The following is a description of a gene set: Human Gene Set: ZHANG_BREAST_CANCER_PROGENITORS_UP species: Mus musculus Genes up-regulated in cancer stem cells isolated from mammary tumors compared to the non-tumorigenic cells. Using a syngeneic p53-null mouse mammary gland tumor model that closely mimics human breast cancer, we have identified, by limiting dilution transplantation and in vitro mammosphere assay, a Lin(-)CD29(H)CD24(H) subpopulation of tumor-initiating cells. Upon subsequent transplantation, this subpopulation generated heterogeneous tumors that displayed properties similar to the primary tumor. Analysis of biomarkers suggests the Lin(-)CD29(H)CD24(H) subpopulation may have arisen from a bipotent mammary progenitor. Differentially expressed genes in the Lin(-)CD29(H)CD24(H) mouse mammary gland tumor-initiating cell population include those involved in DNA damage response and repair, as well as genes involved in epigenetic regulation previously shown to be critical for stem cell self-renewal. These studies provide in vitro and in vivo data that support the cancer stem cell (CSC) hypothesis. Furthermore, this p53-null mouse mammary tumor model may allow us to identify new CSC markers and to test the functional importance of these markers. from publication Zhang M, Behbod F, Atkinson RL, Landis MD, Kittrell F, Edwards D, Medina D, Tsimelzon A, Hilsenbeck S, Green JE, Michalowska AM, Rosen JM (PMID 18559513), and this is the list of marker genes: WDR3, RBBP5, VPS26B, ZFAND4, TOMM70, ECT2, WEE1, CTDSPL2, ADAMTS20, ITGA6, ACYP1, SESN3, SERBP1, KBTBD8, ADGRL3, TCEA1, CAPRIN1, TAF1D, LZTFL1, STMN1, C11orf54, NCBP1, CTTNBP2, COL25A1, PTPN14, UCHL5, SERTAD4, DSG2, TGFA, MLLT3, DEPDC1 (DEP domain containing 1), SRSF3, PSPC1, WDR75, MARCHF6, NFIA, SFPQ, CALM2, POT1, NUP155, ZNF770, RRAGD, ARPP19, BCAP29, IFTAP, MELK, SLC20A2, NFYB, SMNDC1, AUTS2, ACSL3, TIMM17A, LCORL, ZNF367, FAM13B, DUSP11, ARAP2, C1D, MOB4, AP1S3, PPM1B, INTS2, WIF1, MET, NRAS, ABHD13, ZNF362, HNRNPLL, ADK, ARMC10 (armadillo repeat containing 10), SMC4, GPSM2, CDC73, UBE2B, ARNT2, SMCHD1, SBNO1, SEC22C, LSM5, ZNF148 (zinc finger protein 148), HACE1, RPA3, ALG13, ZNF267, CEP43, TIMM21, IPO8, TMEM209, PEX7, SYNCRIP, CRLS1, CEP192, EPS8, LSM7, MYB, STRAP, LRRC40, TRMT6, FGFR1OP2, GMNN, EDARADD, SYDE2, NUP85, LAMTOR5, ANAPC1, PATZ1, ACTL6A, HMGB2 (NCBI Gene Id 3148), NCAPD2, FIRRM, CAV2, POLD3, SETX, PLEKHB1, CNOT6, MDH1, MCM2, YWHAB, CHMP1B2P, TTF2, RIF1 (NCBI Gene Id 55183), TRIM37 (tripartite motif containing 37), TRPM3, TP53BP1, EIF4B, MME, AZIN1, SLC7A1, LRBA, SNX5, ILF3, RBBP8, MRPS31, ANP32E, PIN1, WDR11, SEMA5A, PIGF, BUB1B, CHEK1, N4BP2, MIS18BP1, RNF128, YWHAQ, ZBTB44, PRR14L, MATR3, HELLS, TMTC4, ARL6IP6, CTH, KITLG, NVL, VPS54, SKP2, CTNND2, TRDMT1, FARSB, CAPZA2, PCDH18, UNG, SGO1, RPS3, PSAT1 (NCBI Gene Id 29968), USP34, IMMP1L, TMEM230, MTDH, G3BP2, XRCC5, CDC40, HNRNPDL (heterogeneous nuclear ribonucleoprotein D like), POLA1, TRRAP (transformation/transcription domain associated protein), EFCAB7, RRM2, AJUBA, NUDCD1, MRPS18C, VBP1, BRCA1, ZNF160, ZNF239, TCEANC, BBIP1, STK26, HOOK1, SKA2, PPIP5K2, SLC38A1, COL4A5, HNRNPA2B1, SLC39A10, ZNF24, GPM6B, TTC9C, SHCBP1, MAP7D2, TRAPPC2, SNRPB2, ETFRF1, CDCA8, ING3, UBLCP1, IDH3A, RPS6KA6, ZC3HAV1L, TOP2A, RPA1, PARK7 (NCBI Gene Id 113880), ACTR3B, RAD21, MOXD1, C1orf74, CENPF, CFAP97, JADE1, EIF4H, DBF4, OXCT1, TRIP13, HAT1, VDAC1, ENPP3, AEBP2, SAP30, PARP1, UHRF1, BET1 (NCBI Gene Id 10282), POLR3K, BCL2, AURKA, TRIM59, PFN2, ERI2, CSTF2, PKP4, DCK, ZCCHC8, CETN3, EDAR, PHB2, UBA3, POLR3H, TSPAN13, NEO1, ITGA2, POLR1C, NDUFS4, PRIM1, ASXL1 (ASXL transcriptional regulator 1), MRPS33, KANSL1L, BCLAF3, ANKLE2 (NCBI Gene Id 23141), DNAJA1, PDK1, CD38, TOPBP1, PAIP2 (poly(A) binding protein interacting protein 2), DPY30, ATR, TSPAN2, PCMTD2, ZNF846 (zinc finger protein 846), SMIM15, RELL1, SHMT1, CTCF, TRMT11, KIF16B, CD2AP, ATXN1, C1orf131, PAICS, IK, SSB, SSBP1, PPP4R3B, ANKRD26, RPE, ZNF136, UBA2, NME7, DDR1, RPRD2, CASP8AP2, CEP55, PCYOX1, CPSF6, KIF2C, FIGNL1, BCL11A, SMC2, EZH2, USP1, RNF6, UBE2D2, ZNF878, RNF44, PABPC4L, MED6, TP63, ZIK1, ATAD1, NAF1, ZFAND6, RNMT, NFU1, STXBP6, PUS7L, SPIN1, CDKL5, CLDN12, ERCC6L2, NEK1, HARS1, TULP3, PDS5B, STRBP, POLR2B, NAE1, HUS1, ZRANB2, EMID1 (EMI domain containing 1), RBM45, METTL9, PHF14, CCDC90B (NCBI Gene Id 60492), BUB1, TRAPPC10, TFRC, PRELID3B, ANLN, SUCLA2 (succinate-CoA ligase ADP-forming subunit beta), PPAT, CA12, UGDH, UTP15, ZNF532, SNAPIN, MPHOSPH8, NDUFA4, CRYZ, CHCHD4, PWP1, GRHL2, TMEM33, EID1 (NCBI Gene Id 27110), C21orf91, PLCB1, RAD51, NOL4L, PHF6, ATAD2, RPL15 (NCBI Gene Id 6138), PANK1, PPP2R1A, PRPS2, HNRNPU, CDC25A, PAXBP1, CDC6, HNRNPA3, CEP164, CDCA7 (cell division cycle associated 7), MPZL1, RIDA, EWSR1, NANP, ADH5, GEMIN6, TASP1, TAF2, ZNF22, GTPBP10, PROM1, MTHFD1, FAM76B, MBNL3, XPO1, ESCO2, PBK, IFT81, CCNA2, FAM199X, RFX3, RBAK, SLF1, LMBRD2, RFC1, TMPO, SGO2, PDZD8, TTC3, GTF2H2, RBL1, GSDME, EFTUD2, NDUFC2, TNIK, NCAPG, BRD7, ST6GAL1, H2AZ1, DLAT, BMI1, ORC5, PACSIN2, APPBP2, NCAPD3, ACAT2, CD24, TAX1BP1, AHCY (NCBI Gene Id 191), ZNF317, KCTD15, NUP107, AHR, TRPS1, ACTR6, VDAC3, NDUFC1, GLRB (NCBI Gene Id 2743), TMEM117, SRSF10, E2F7, AKAP9, RNF7 (ring finger protein 7), STARD7, DNAJC9, FH, SMARCA5